Given this list of marker genes CDYL2, WNT3, MBD2, SPOPL, TUBB6, AAK1, SCN9A, MRE11, KATNA1, TOGARAM1, FRMD5, TMEM65, ELOC, ZCCHC2, MTERF3, RTF1, PPM1A, TLK1, ACER3, COX18, POLD3, CHST11, RAP2C, CILK1, C5orf24, DDX53, ZNF680, ZNF92, SLC38A2, BCL11A, CTNNB1, SCAMP1, FOXL2NB, KCNJ6, ST8SIA6, RIMS2, ATP1B1, SLC66A3 (NCBI Gene Id 130814), YTHDC1, TEX101, MGAT4A, WAPL, RHOT1, RUNX2, PPM1F, GBE1, PSIP1, ITPA, NAB1, RAPGEF6, C18orf63, TACC2, PICALM, RPL13, DACH1, SLC15A2, VSNL1, NFAT5, LMO7, POGLUT2, SLC25A27, SEC23IP, KLF12, ANLN, USP15, KCTD9, MAST4, CCNYL1, FNDC3B, KCNH5, TXNDC16, KLHL29, ATG7, CREB5, ATP8A1, ANO3, RAB4A, KCTD20, ADGRG6, PANK1, ATP9A, PTPN21, ACVR2B, ZNF257, SEMA3A, DACH2, EZH2, KRAS, FAM98A, CHN2, DACT1, REST, HNF1B, FBN2, SOS1, GPM6A, PDE12, PRKAR2B, ERCC6, NSUN3, MAMDC2, MYEF2, MIER3, STT3A, KIAA0408, BDKRB2, ALDH16A1, PCNA, ASXL3, DOCK3, ZBTB24, HIVEP3, MPHOSPH9, LINC03042, TDO2, FAM169A, ATP11C, HIPK3, GKAP1, PROX1, YOD1 (YOD1 deubiquitinase), FGFR2, HS3ST3A1, PPP4R2, TMTC4, HSPA9, USP27X, UBL3, G6PC1, APPBP2 (amyloid beta precursor protein binding protein 2), GXYLT1, ADGRB3, LPAR1, GRIK2, NUP214 (NCBI Gene Id 9680), ATF1, CA8, PPM1D, SH3PXD2A, DNA2, URB2, TTC28, here is a description of the gene set: from publication Chen Y, Wang X (PMID 31504780) Human Gene Set: MIR6807_3P Genes predicted to be targets of miRBase v22 microRNA hsa-miR-6807-3p in miRDB v6.0 with MirTarget v4 prediction scores > 80 (high confidence targets). species: Homo sapiens